Given this list of marker genes IRF2BPL, ATF1, SYS1, LARP1B, SYNC, SLC35G1, PTHLH, DLL1, CPEB4, LHFPL2, RBM12B, PAN3, SGIP1, RBM27, OLIG3, STRN3, EDEM1, AVL9, RPS6KB1, RMI1, NEXMIF, ERICH3, SUZ12, CENPK, CASTOR3P, PRKCA, TRIM50, LUC7L3, DENND6A, PEG10 (paternally expressed 10), LHFPL1, PLAGL2, SNX18, CALHM5, TNFSF13B, HDAC2 (NCBI Gene Id 3066), EIF3A, ACSL6, ALS2, TLE4, NOL4, RSPO2, RAPGEF6 (NCBI Gene Id 51735), CNGB1, IDH1, CYP1B1, PLP1, CHSY1, ADCYAP1R1, PRKACB, PLXNB1, ALDH6A1, TMEM182, MRPS18C, MRPL35, PIKFYVE, here is a description of the gene set: from publication Chen Y, Wang X (PMID 31504780) Human Gene Set: MIR362_5P Genes predicted to be targets of miRBase v22 microRNA hsa-miR-362-5p in miRDB v6.0 with MirTarget v4 prediction scores > 80 (high confidence targets). studied in species Homo sapiens